The following is a description of a gene set: from publication Chen Y, Wang X (PMID 31504780) Genes predicted to be targets of miRBase v22 microRNA hsa-miR-409-5p in miRDB v6.0 with MirTarget v4 prediction scores > 80 (high confidence targets). studied in species Homo sapiens Human Gene Set: MIR409_5P, and this is the list of marker genes: USP53, SMIM43, CGGBP1, HYCC1, ASPH, TMC5, PCLO, GPAT3, TRPS1, ACAT1, CBLN2, USP7, MKRN1, MARCKS, PAOX, CPSF6, KDM5A, KDM4D, LRRC57, ANKRD13C, CREM, AK9, ACVR2B, NAIP, RUFY2, HMBS, MAPK1IP1L, PDAP1, NADK2, LRTM2, ADAM10, SEMG1, GNG12, PAX9, ZBTB34, MINDY2, NETO2, CAMTA1, LRP8, CEP43